The following is a description of a gene set: Modulates the activity of a phosphatidylinositol 3-kinase (PI3K). Regulatory subunits can link a PI3K catalytic subunit to upstream signaling events and help position the catalytic subunits close to their lipid substrates. Human Gene Set: GOMF_PHOSPHATIDYLINOSITOL_3_KINASE_REGULATOR_ACTIVITY studied in species Homo sapiens, and this is the list of marker genes: PIK3IP1, FLT3 (NCBI Gene Id 2322), PIK3R1, KLF4, PRKD1, WDR91, SH3GLB1, RUBCN, ATG14, LYN, WDR81, WASHC1, AGAP2 (ArfGAP with GTPase domain, ankyrin repeat and PH domain 2), IRS2